The following is a description of a gene set: Human Gene Set: HP_ABNORMAL_BOWEL_SOUNDS studied in species Homo sapiens An anomaly of the amount or nature of abdominal sounds. Abdominal sounds (bowel sounds) are made by the movement of the intestines as they promote passage of abdominal contents by peristalsis. Abnormal bowel sounds, and this is the list of marker genes: CAV1, TYMP, CCN2, SLC5A1, HLA-DRB1, POLG, SDHD, CCR6 (C-C motif chemokine receptor 6, NCBI Gene Id 1235), IRF5, ATRX